The following is a description of a gene set: species: Homo sapiens Transcription of the NPAS4 gene is positively regulated by neuronal stimulation-related increase in intracellular calcium levels.<br><br>In the absence of neuronal activity induced calcium influx, KCNIP3 (DREAM) binds to the promoter of the NPAS4 gene and represses NPAS4 transcription. In non-neuronal cells, REST protein represses transcription of the NPAS4 gene. In neuronal cells, REST may have a dual effect on NPAS4 expression: acting as a positive regulator of NPAS4 transcription early upon neuronal excitation and as a negative regulator at later time points, allowing NPAS4 to return to basal levels. Binding of agonist activated glucocorticoid receptor NR3C1 (also known as GR) to evolutionarily conserved glucocorticoid response elements (GREs) upstream of the NPAS4 gene transcription start site is responsible for stress-induced repression of NPAS4 gene transcription (Furukawa Hibi et al. 2012). Chronic restraint stress as well as corticosterone injection also reduce Npas4 gene expression in the mouse hippocampus. Though mechanisms remain to be delineated, HDAC5 was reported by multiple studies to contribute to NPAS4 gene repression. In addition, HDAC3 was reported as the NPAS4 gene repressor during neurodegeneration (Louis Sam Titus et al. 2019).<br><br>SRF (Serum response factor) stimulates NPAS4 gene transcription upon neuronal excitation. NPAS4 gene transcription is positively regulated by PI3K/AKT signaling, and only partially dependent on ERK (MAPK) signaling. NPAS4 may be one of the EGR1 target genes. Neuronal activity stimulation may trigger the formation of DNA double strand breaks (DSBs) in the promoters of a subset of early-response genes, including FOS, NPAS4, and EGR1, which may contribute to their transcriptional activation. NPAS4 appears to be a downstream target involved in amyloid precursor protein (APP)-dependent regulation of inhibitory synaptic transmission. TET1, a methylcytosine dioxygenase that catalyzes oxidation of 5-methylcytosine (5mC) to 5-hydroxymethylcytosine (5hmC) and promotes DNA demethylation is implicated in transcriptional activation of NPAS4 gene through demethylation of hypermethylated CpG dinucleotides in the NPAS4 gene promoter region. Transcriptional activation of the NPAS4 gene is associated with the appearance of H3K4me3 mark and 5hmC mark at the NPAS4 gene promoter. part of: Regulation of NPAS4 gene expression Reactome Pathway: Regulation of NPAS4 gene transcription, and this is the list of marker genes: SRF, NPAS4, REST, KCNIP3 (potassium voltage-gated channel interacting protein 3), NR3C1